The following is a description of a gene set: Genes up-regulated in monocytes (6h): muramyl dipeptide versus M. tuberculosis 19 kDa lipopeptide. from publication Schenk M, Krutzik SR, Sieling PA, Lee DJ, Teles RM, Ochoa MT, Komisopoulou E, Sarno EN, Rea TH, Graeber TG, Kim S, Cheng G, Modlin RL (PMID 22447076) human blood monocytes were isolated, activated and harvested at several timepoints In this study, we identified genes that were differentially expressed in human monocytes activated with eiter NOD2L and/or TLR2/1L. Human Gene Set: GSE34156_NOD2_LIGAND_VS_TLR1_TLR2_LIGAND_6H_TREATED_MONOCYTE_UP studied in species Homo sapiens, and this is the list of marker genes: CYP26A1, TNFSF10, CHP1, MAFK, TBRG1, FES, CLIP2, STX3, PSMD7, RNF19B, C2CD3, CRYBG1, USP18 (NCBI Gene Id 11274), TSPYL1, TRIB3, DUSP1, MPEG1, MOV10, PSMB10, TAPBP, LY6E, KLF4, OTUD5, ISG15, RBCK1, VPS54, CLIC4, IFIT1B, FBXW11, ANKRD17, TGIF1, TFR2, IL18BP, DTX2, ANGPT1, MARCHF5, VCAN, ACP5, JUN, IRS1 (NCBI Gene Id 3667), PSMB9, SAP30 (NCBI Gene Id 8819), PTPN14 (protein tyrosine phosphatase non-receptor type 14), UBE2L6, DAXX, SHISA5, SPTLC2, MAP3K11, NISCH, ISOC1, NUB1, UBA7, OGFR, TAP2, GNB4, TBPL1, SFMBT2, MAP2K1, CD47, PFN1, SOCS1, DYNC1H1, TRAF3IP2, ISG20, MX2, PIPOX, LHX6, GHRH, TNFRSF1B, ARG2, RSRP1, SERPINB9, PML, GNA13, TCIRG1, PI4K2A, LY6D, CHIC1, NGDN, PCNT, CMTR1, IL11, MX1, JAK2, HMGCS2, FRMD5, FNDC3A, MAGEL2, IL6, SERPINB6, SLFN12L, ZFP36, AGRN, STAT1, BARD1, PSME2, PCGF5, AKR1B1, CBX4, TOR3A, PTPN13, FGF10, SLC10A1, FBXW4, IFITM3, RORC, RNPEPL1, TUT7, EIF2AK2, IRF1, DLX1, IRF5, SLC7A3, ZNFX1, POU3F2, IRF7, CASP4, TSC22D3, GBP4, HLA-B, NDST2, IL15, CXCL10, PELI1, GBP2, PSMB8, LGALS9B, TRAFD1, ANKFY1, IFI35, SLC25A44, N4BP1, IRGM, PNP, ITM2B, XDH, BMP10, NAMPT (nicotinamide phosphoribosyltransferase), PSME1, OSER1, SOCS2, CASP12 (caspase 12 (gene/pseudogene)), CPNE3, GBP7, IRF9, TTC27, CCNL2, KCND3, MYD88, RMDN3, TRAF5, NMI, FMR1, DDX24, DLL1, STXBP1, OSMR, SSBP2 (NCBI Gene Id 51492), SAMHD1, TRIM25, IFIT2, TNFAIP8, RSAD2, DUSP16, NPC2, IFIH1 (NCBI Gene Id 64135), TRIM21, GRINA, COX7A1, CCDC6, C8orf33 (NCBI Gene Id 65265), IFIT3, PNPT1, IL9R, IKBKG, TERF1 (NCBI Gene Id 7013), IL13RA1, RAP1GDS1, HLA-C, TAP1, FASTK, TOR1AIP2, TNFRSF4, TWIST1, ETNK1, HSDL2, COP1, NFE2L1, PRKCE, GADD45G, F7, IFNGR1, APOD, SPSB1, TXNIP, CTPS1, LGALS3BP, RFX2, ADAR, APOBEC1